Given this list of marker genes SAMM50, TIMM17A, GRPEL2, TOMM22, SFXN2, AFG3L2, TOMM40L, TOMM20L, ITPR1, SLC25A23, MICU3, SPG7, SFXN1, DNAJC15, SLC25A33, PAM16, SLC25A39, MICU2, TIMM50, SLC25A38, TOMM70 (translocase of outer mitochondrial membrane 70), SFXN3, MICU1, GRPEL1, TOMM40, HSP90AA1, TIMM23, PNPT1, PSEN2, DNLZ, TIMM17B, SMDT1, UCP2, ROMO1, MCU, SLC30A2, MRPL18, SLC25A28, SLC25A37, TIMM23B (translocase of inner mitochondrial membrane 23 homolog B), DNAJC19 (NCBI Gene Id 131118), MCUR1, MCUB, MAIP1, TOMM20, SLC25A40, TIMM21, TOMM7, TIMM44, VDAC1 (voltage dependent anion channel 1), TST, HSPA9, HSPA4, SLC25A36, here is a description of the gene set: Human Gene Set: GOBP_IMPORT_INTO_THE_MITOCHONDRION The directed movement of substances from the cytosol into the mitochondrion. species: Homo sapiens